Given this list of marker genes Dpf2 (double PHD fingers 2), Cbx7, Kdm4c, Hdgfl2, Chd5, Taf7, Brd7, Cbx2, Fgf2, Taf1 (NCBI Gene Id 270627), Cbx5, Zcwpw1, here is a description of the gene set: Mouse Gene Set: GOMF_HISTONE_H3_READER_ACTIVITY species: Mus musculus A histone reader that specifically binds either to an unmodified histone H3 or a form modified by a post-translational modification on a specific residue. The most common PTMs on histones are methylation, acetylation and phosphorylation.